The following is a description of a gene set: from publication Yagüe E, Arance A, Kubitza L, O'Hare M, Jat P, Ogilvie CM, Hart IR, Higgins CF, Raguz S (PMID 17283147) studied in species Homo sapiens Up-regulated genes common to all pretumorigenic cells with acquired drug resistance. Human Gene Set: YAGUE_PRETUMOR_DRUG_RESISTANCE_UP Resistance to chemotherapy is one of the principal causes of cancer mortality and is generally considered a late event in tumor progression. Although cellular models of drug resistance have been useful in identifying the molecules responsible for conferring drug resistance, most of these cellular models are derived from cell lines isolated from patients at a late stage in cancer progression. To ask at which stage in the tumorigenic progression does the cell gain the ability to acquire drug resistance, we generated a series of pre-tumorigenic and tumorigenic cells from human embryonic skin fibroblasts by introducing, sequentially, the catalytic subunit of telomerase, SV40 large T and small T oncoproteins, and an oncogenic form of ras. We show that the ability to acquire multidrug resistance (MDR) can arise before the malignant transformation stage. The minimal set of changes necessary to obtain pre-tumorigenic drug-resistant cells is expression of telomerase and inactivation of p53 and pRb. Thus, the pathways inactivated during tumorigenesis also confer the ability to acquire drug resistance. Microarray and functional studies of drug-resistant pre-tumorigenic cells indicate that the drug efflux pump P-glycoprotein is responsible for the MDR phenotype in this pre-tumorigenic cell model., and this is the list of marker genes: PHLDA1, SALL1, ABCB1, SLC16A14, FENDRR, TBC1D8, HSD17B2, MAN1C1